Given this list of marker genes CREBBP, PLEKHG6, RARA, CREB5, SPAG9, RBM3, HS3ST2, TENT5A, KRT2, NME1, HNRNPA0, RBM39, GRIA1, RAN, EBF2, NIPBL, RBFOX1, TLX3, LINC02363 (long intergenic non-protein coding RNA 2363), BEST3, GPX1, SUPT16H, CFL2, UBR1, ECM2, CPEB4 (cytoplasmic polyadenylation element binding protein 4), HOXA3, SLC3A2, UBE2B, NLGN2, ZNF710, E2F8, EAF1, LYPD1, DENND5A, PPIE, SMARCA2 (SWI/SNF related, matrix associated, actin dependent regulator of chromatin, subfamily a, member 2), HECTD2, TXNRD1, MYH13, FAF1, UBXN10, LAMC1, ABI3BP, SMIM43, BUD31, GSC, CDKN2B, CFAP161, MED19, ZBTB37, BRD8, SOBP, UBE2E3, GAB2, NR2F1 (NCBI Gene Id 7025), EBF1, RBP5, CUTA, WDR20, C6orf62, GRK6, ALX4, RAB22A, SLTM, CREBZF, MINK1, MAP1A, MED13, LNPK, BPIFA3, PCSK5, MID2, HOXB3, JMJD1C, CLIP3 (NCBI Gene Id 25999), LRRTM3, ZFHX4, STAG2, HAGH, CDX1, MAP2, ARL6IP4, ST13P4, ATP1B1, PCYT1B, DLG2, PHF23, CNTF, RIT1, CD247, HEBP1, KDM6A, CCDC80 (NCBI Gene Id 151887), MAGED1, ELOA, UGT2B10, PHLPP1, MARCHF1, CTSK, TLK1, AIG1, PCSK2, SAT1, DLL1, DCLK2, IGSF22, PDAP1, RPS6KA3, JDP2, GRIK3, EIF4E, AK5, DCAF8, NRG1, JAG1, CA7, FOXP2, TMX2, CCR1, EFHD1, DLX3 (NCBI Gene Id 1747), ZFR, CCND2, ENTHD1 (ENTH domain containing 1), PEX5L, SIM1, CASZ1, PKLR, NAA38, SYNRG, SATB2, NREP, IL24, BDNF, HNRNPR, CHD2, RNF13, KIF1C, OR10A5, POU3F4, SLITRK2, FGF10, STAT3, SMARCD3 (SWI/SNF related, matrix associated, actin dependent regulator of chromatin, subfamily d, member 3), TNR, PAX7, TMEM88, METTL6, ANGPT1, RNF128, SKIDA1, IFT20, GPC4, CAMSAP1, ZNF582, HIC1, MITF, THBS1, KMT2A, SRPK2, TEX44, RIMS2, MB, KCNA1, LURAP1L, BEND4, SLC4A3 (solute carrier family 4 member 3), GARIN1B, SLC41A2, RLIM, TIMM17A, DMD, HOXC6, EMSY, VCP, SGIP1, ZDHHC21, LMAN1, TFDP2, RSRC1, ZIC4, CLSTN3, NUP54, CNTLN, LRRTM4, MNT, PRG4, S1PR1, PTCH1, PTRH2, SEL1L, LRRC57, FABP4, SPARCL1, VMP1, MPV17, PDZD2, SHISA6, ZNF185, EXPH5, FHL2, LMBRD1, EDAR, ZHX2, TNFAIP1, PAX2 (NCBI Gene Id 5076), ESM1, NTRK3, MAPT, TSPAN17, NANOS1, CNTN2, CRLS1, ELAPOR1, NDST4, NR4A3 (nuclear receptor subfamily 4 group A member 3), NCKAP5, CADM1, PPM1A, AKIRIN2, POU2F1, TGFB3, JAKMIP2, MYT1, PHF21A, MBNL2, ENSG00000204117, HAUS2, MAP2K5, CYB5D1, CCDC88A, VPS45, SORBS1, BTK, CACNG2 (NCBI Gene Id 10369), INCA1, UBE2A, NRP1, FBXO36, COL9A1, IRX5, KCNK12, SLC6A5, KIF1B, PI16, SRSF6, ELF5, ITGAM, ITGB6, UBE2K, GNAI1, SYNPR, ZSWIM8, TOMM40L, CCND1, TNRC6A, PDE4D, here is a description of the gene set: Genes having at least one occurrence of the motif GTCATNNWNNNNN in the regions spanning 4 kb centered on their transcription starting sites. This matches the NFE2L1 transcription factor binding site V$TCF11_01 (v7.4 TRANSFAC). Human Gene Set: TCF11_01 species: Homo sapiens